Given this list of marker genes FSD1L, GTDC1, FCGR1BP, SFR1, MAP3K4, C1orf21, RAB33A, IER3, ANKLE2, RALGAPA1, SLAMF1, HYCC1, ANXA7, MTF1, HLX, STEAP1, IL6 (interleukin 6), EZH2, LCOR, PELI1, NEDD4, GK5, SLC7A7, USP12, FLT1, IL23A, STAT4, SVIL, CASP5 (NCBI Gene Id 838), PLAT, KANK1, IL7R, BACH1, B3GNT2, PDE8A, ENPP2, TNFRSF1B, SURF4, ZFR, MAP4K4, ERVMER34-1, ATL3, PRRC1, HES1, SASH1, RGL4, BCL2A1 (NCBI Gene Id 597), VAV1, ASAP2, GADD45B, TRIP10, ARHGAP24, CEMIP, SOS1, HDAC9, FBXO39, ITGB8, SIGLEC15, SPATA6, PNPLA8, ENPP4, SNAPC1, VNN3P (vanin 3, pseudogene), ELL2, NDP, RBM17, STON2, GADD45A, SMPDL3A, RUBCNL, OTUD1, REST, ZNF319, FPR2, PAPSS2 (3'-phosphoadenosine 5'-phosphosulfate synthase 2), PIKFYVE, SAMSN1, IL6-AS1, MFSD2A, HCAR3, MED16, IL36G (NCBI Gene Id 56300), THAP1, MIR3945HG, TNIP3, LIMK2, PLAGL2, BASP1 (brain abundant membrane attached signal protein 1), CDKN2A, SOCS1, CDC42EP3, FRMD6, MAP3K1, SLC22A1, SERPINB1, C11orf96, GNG2, IL15RA, ATF7IP, SLC25A45, MAP3K5, HAS1, FERMT2, SERPINB7, ACP3, LLGL2 (NCBI Gene Id 3993), CSF2, LMO2, SLC37A3, CD274, VNN2, RHNO1, LINC01093, SLC16A10, FJX1, SYT17, PTEN, MCTP2, HEBP2, STRIP2, CLGN, BAALC, MIR155HG, TFRC, STK26, STAT3, PTX3, KDM7A, PLA2G4A, SOCS3, PIM1, PLGRKT, MRPS10, C18orf21 (NCBI Gene Id 83608), SAP30BP, MGAT2, AGFG1, GRAMD1A, PLAC8, TNFRSF8, KLF6, AGO2, IL19, TP53BP2, HMGCS1, MRPL52, TRIM36, PDSS1, ETV3, CHI3L1, ABHD17C, TBC1D30, BATF, IL2RA, SLC25A37, ZC3H12A, TGFA, TRAF3IP2, NEDD4L, PIK3AP1, KTN1, SLCO4A1, GJB2, PTGS2, CXCL2, TM4SF1, IER5, RPS6KC1, TNFAIP8, LRIG1, P2RY2, IL10, EHF, WTAP, IL4R, TRAF1, ABTB2, PTPN2, TNFAIP6, ADGRE1, OAZ3, NKX3-1, IL7, RND1 (Rho family GTPase 1), CSF3, THRAP3, AQP9, CYB5R2, DLL1, FBXL3, GFPT2, FCAMR, IL24, TLR8, LILRB2, LDLRAD3, IL12B, PLD1, here is a description of the gene set: Human Gene Set: GSE30971_WBP7_HET_VS_KO_MACROPHAGE_2H_LPS_STIM_DN Genes down-regulated in bone marrow-derived macrophages treated with LPS for 2h: heterozygous versus homozygous knockout of MLL4. Histone methyltransferases catalyze site-specific deposition of methyl groups, enabling recruitment of transcriptional regulators. In mammals, trimethylation of lysine 4 in histone H3, a modification localized at the transcription start sites of active genes, is catalyzed by six enzymes (SET1a and SET1b, MLL1–MLL4) whose specific functions are largely unknown. By using a genomic approach, we found that in macrophages, MLL4 (also known as Wbp7) was required for the expression of Pigp, an essential component of the GPI-GlcNAc transferase, the enzyme catalyzing the first step of glycosylphosphatidylinositol (GPI) anchor synthesis. Impaired Pigp expression in Wbp7-/- macrophages abolished GPI anchor-dependent loading of proteins on the cell membrane. Consistently, loss of GPI-anchored CD14, the coreceptor for lipopolysaccharide (LPS) and other bacterial molecules, markedly attenuated LPS-triggered intracellular signals and gene expression changes. These data link a histone-modifying enzyme to a biosynthetic pathway and indicate a specialized biological role for Wbp7 in macrophage function and antimicrobial response. from publication Austenaa L, Barozzi I, Chronowska A, Termanini A, Ostuni R, Prosperini E, Stewart AF, Testa G, Natoli G (PMID 22483804) species: Homo sapiens